The following is a description of a gene set: studied in species Homo sapiens Genes down-regulated in comparison of naive CD4 CD8 T cells versus monocytes cultured for 0 days. from publication Abbas AR, Baldwin D, Ma Y, Ouyang W, Gurney A, Martin F, Fong S, van Lookeren Campagne M, Godowski P, Williams PM, Chan AC, Clark HF (PMID 15789058) Human Gene Set: GSE22886_NAIVE_TCELL_VS_MONOCYTE_DN Immune cell-specific expression is one indication of the importance of a gene's role in the immune response. In order to identify such patterns, we set out to broadly profile gene expression in a variety of immune cells., and this is the list of marker genes: TOR4A, FEZ2, CAPG, ACSL1, ATP6V1B2, MID1IP1, HEXB, GLRX, GAPDH, IGSF6, APOBR, PPP1R3D, SLC27A3, SMCO4 (single-pass membrane protein with coiled-coil domains 4), SCPEP1, IFNGR1, CTBP2, CD33, TNS3, FPR1 (NCBI Gene Id 2357), DEF8, GAB2, ATP6V1A, LGALS3, KCNMB1, LY96, ATP6V0B, VAMP3, LILRB3, TNFRSF1B, LTBR, CERT1, FTL, CLEC7A, SLC11A1, CCR1, BACH1, HSPA1A, PTTG1IP, BCKDK, ZMIZ1, QPCT, RHOQ, FCGR2A, PTPRE, STX7, NPL (N-acetylneuraminate pyruvate lyase), PGD, TALDO1, LAPTM5, ABHD5, MARCKS, RTN1, LILRA2, TLR2, SLC7A7, UBE2D1, CEBPB, DUSP3, GLUL, CORO1C, GRN, GNS, PILRA, ATP6V0D1, CSF2RB, GCA, LILRB1, NAGK, NCF1C, SEMA4A, ADAP2, BID, CTNNA1, S100A12, USP15, CD93 (NCBI Gene Id 54591), TNFRSF10B, CYBB, RXRA, NCF4, MSRB1, SNX11, NOTCH2, DPYD, S100A11, CPVL, ATG7, STX12, COQ2, PRKCD, SLC16A6, SH2B3, HK3, MGAT1, MTMR11, MNDA, PTGS1, ARHGAP26, NADK, CCDC88A, CD36, CDC42EP3, CLEC4A, SLC31A2, TBC1D2, CASP1, IFNGR2, PICALM, FGR, CD14, DMXL2, GLB1, PLAGL1, NOD2, LILRA6, CEBPD, AKR1A1, RIN2 (Ras and Rab interactor 2), CTSB, SYK, FBP1, EXOC1, CYRIA (CYFIP related Rac1 interactor A), NCF2, DIAPH2, SH3TC1, DAPK1, PSAP, FUT4, CSTA, EXT1, NCOA4, OAZ1, DHRS7B, TPP1, PCTP, BCL6, ZFAND5, RAB32, METTL9, CSF3R, SIRPA, PLXNC1, DICER1, GPX1, ASAH1, FGL2, TBC1D12, ARHGEF40, FKBP15, S100A9, CREG1, STX3, AP1S2, MANBA, WASHC4, PLBD1, CHST15, LAT2, MCTP1, MTMR14, SNX10, TIMP2, IFI30, SUOX, DUSP6, APOBEC3A, SIGLEC9, GABARAP, ARHGEF10L, CTSH, BCL2L2, GRK3, PEA15, NEU1, RNF130, PISD, TNFAIP2, SDCBP, PLXNB2, MFSD1, RBM47, NPC2, TNFSF13 (NCBI Gene Id 8741), APLP2, FLVCR2, KCTD12, ARAP1, IRAK3, VNN2, PTAFR, NLRP3, VCAN, TMEM127, HS1BP3, PLSCR1 (phospholipid scramblase 1), SLC15A3, PDLIM5, CKAP4